The following is a description of a gene set: Mouse Gene Set: REACTOME_ERYTHROPOIETIN_ACTIVATES_RAS species: Mus musculus Erythropoietin activates RAS, and this is the list of marker genes: Shc1, Crkl, Vav1, Irs2, Epor, Jak2, Lyn, Rapgef1, Epo, Grb2